The following is a description of a gene set: The TRAP/Mediator coactivator complex serves as a functional interface between DNA-bound transactivators and the RNA polymerase II-associated basal transcription apparatus. TRAP220/MED1 is a variably associated subunit of the complex that plays a specialized role in selectively targeting TRAP/Mediator to specific genes. Ablation of the Trap220/Med1 gene in mice impairs embryonic cell growth, yet the underlying mechanism is unknown. In this report, we identified distinct cell growth regulatory genes whose expression is affected by the loss of TRAP220/MED1 by RNA interference. Among the down-regulated genes revealed by cDNA microarray analyses, we identified Aurora-A, a centrosome kinase that plays a critical role in regulating M phase events and is frequently amplified in several types of cancer. In general, we found that TRAP220/MED1 expression is required for high basal levels of Aurora-A gene expression and that ectopic overexpression of TRAP220/MED1 coactivates transcription from the Aurora-A gene promoter. Furthermore, chromatin immunoprecipitation assays show that TRAP220/MED1-containing TRAP/Mediator complexes directly bind to the Aurora-A promoter in vivo. Finally, we present evidence suggesting that TRAP/Mediator is recruited to the Aurora-A gene via direct interactions between TRAP220/MED1 and the Ets-related transcription factor GABP. Taken together, these findings suggest that TRAP220/MED1 plays a novel coregulatory role in facilitating the recruitment of TRAP/Mediator to specific target genes involved in growth and cell cycle progression. from publication Udayakumar TS, Belakavadi M, Choi KH, Pandey PK, Fondell JD (PMID 16574658) Genes up-regulated in HeLa cells after knockdown of MED1 by RNAi. studied in species Homo sapiens Human Gene Set: UDAYAKUMAR_MED1_TARGETS_UP, and this is the list of marker genes: UBR5, MAD1L1, DICER1, FECH, PHB1, CEP70, PSAT1, RPL22, CASC19, ME2, TMED7, TCF25, ANP32E, DDHD2, STX6, NIT2, PSPH, CCNJ, CHAF1A, OSBPL8, SLC19A1, CD47, CTNND1, APEH, AURKA, LBR, LARP4 (NCBI Gene Id 113251), DHFR, SDC1, FEM1B, EIF2AK2, PCLAF (NCBI Gene Id 9768), AKR1A1, ECPAS, DCP2, SLC35A2, BPGM, PAWR, PUM3, TSPAN4, RBM47 (NCBI Gene Id 54502), TLE6, MYO19, GCH1, TMPO, SLC29A1 (solute carrier family 29 member 1 (Augustine blood group)), CDC6, SSX2IP, CBS, PTMA, RABL6, LRRC14, EIF3A, MED1, PHF10, HNRNPA3, PITX1, AIMP2, TSFM, SUB1, ECEL1, SRGN, GRSF1, CAV2, PTER (phosphotriesterase related), CAMSAP2, EMC8, AP1S2, DARS1, LIG3, SLK, NAGLU (N-acetyl-alpha-glucosaminidase), MRPL42, PFKL, GATD3, EXPH5, AMMECR1, FKBP14, THOP1, CHPT1, OGG1, EDF1, SLC16A3, MBNL1, LONP1, PKN2, SREK1IP1, BRD9, CNOT6, HIGD1A, RO60, LRP8 (NCBI Gene Id 7804), NSMAF, EIF4EBP1, SLC16A1, EML4, RHOQ, SF3A2, ACSL3, ASNS, RDH11, ME1, ZNF580, MALT1, PPP3CB, SCRN3, PTPRF, DTYMK, ANAPC5, RYK, PJA2, DHX15, KLHL23, SEPTIN6, IPO7, TSPAN12, RC3H2, KATNB1, FAAP100, MTDH, POLR3G, DUS1L, NF1, RMND5A, ZMYND11, ANTKMT, CREB1, METRN, PANK4, SDF2L1, FDX1, MRPL12, ASPH, BOP1, GARS1, POGLUT2